Given this list of marker genes CDH17, PLEKHA7, CDH20, DSP, VEGFA, EFNB2, CDH5, PLEC, CTNNB1, KIFC3, CDH24, CDH22, BMP6, CDHR3, CDH11, CDH26, DSG3, NUMBL, CDH2, MTSS1, PTPN23, CDH12, CDH13, ACTB, CDC42, HIPK1, CDH7, ABI2, RDX, TJP1, DLG5, CDH19, EPHA4, CDH15, JAM3, FER, VCL, RAMP2, CDH9, CDH8, INAVA, ADAM10, ADD1, CDH4, PIP5K1C, CAMSAP3, ZNF703, CDH6, CDH10, NUMB, FERMT2, CDH18, TBCD (NCBI Gene Id 6904), CSK, SMAD7, PAK2, SPECC1L, CDH3, CDH1, here is a description of the gene set: A process that is carried out at the cellular level which results in the assembly, arrangement of constituent parts, or disassembly of an adherens junction. An adherens junction is a cell-cell junction composed of the epithelial cadherin-catenin complex at which the cytoplasmic face of the plasma membrane is attached to actin filaments. studied in species Homo sapiens Human Gene Set: GOBP_ADHERENS_JUNCTION_ORGANIZATION